Given this list of marker genes Gsk3b, Septin9, Pik3r1, Clrn1, Ccl21a, Espn, Dzip1, Rp1, Cdc42ep1, Ift88, Mien1, Tgfb3, Tmem67, Arpc2, Cep120, Mtor, Auts2, Cenpj, Eps8l2, Cdc42ep2, Carmil2, Nckap1, Hap1, Dpysl3, Zmynd10, Palm, Ccdc88a, Fmr1, Ccl21d, Tapt1, Pqbp1, P2rx7, Dnm3, Agrn, Mns1, Fuz, Nrp1, Ift20, Fscn1, Ccl21e, Cobl, Ppp1r35, Brk1, Dock11, Kctd17, Cdc42ep4, Eps8l3, Neurl1a, Eps8, Srf, Fam98a, Actr3, Actr2, Wasf2, Rac1, Tenm1, Rala, Dynll1, Cdc42, Plppr5, Htt, Gm14137, Mark4, Eps8l1, Wrap73, Myo3b, Ripor2, Abi2, Aqp1, Zmynd8 (zinc finger, MYND-type containing 8), Fnbp1l, Wasl, Wnt1, Nlgn1, Kit, Rab11fip3, P2ry12, Atp7a, Gpm6a, Tenm2, Akirin1 (NCBI Gene Id 68050), Apc, Frmd7, Plekhm1, Pfn1, Ttbk2, Ccl21b, Ccl21f, Plek2, Atmin, Ccr7, Cfl1, Cyfip1, Dnm2, Entr1, Hdac4, Myo3a, Anln, Prkcq, Cdc42ep3, Ccl19, Bbs4, Crocc, Plce1, Ccp110, Hras, F2rl1, Twf2, Rhoq, Mstn, Saxo1, Ndel1, Arhgap35, Avil, Tgfbr1, Cep135, Rac2, Hsp90aa1 (NCBI Gene Id 15524), Arap1, Cdc42ep5, Rab3ip, Def8, here is a description of the gene set: species: Mus musculus Any process that activates or increases the frequency, rate or extent of plasma membrane bounded cell projection assembly. Mouse Gene Set: GOBP_POSITIVE_REGULATION_OF_PLASMA_MEMBRANE_BOUNDED_CELL_PROJECTION_ASSEMBLY